The following is a description of a gene set: Genes down-regulated in comparison of lineage negative versus B cells. studied in species Homo sapiens Human Gene Set: GSE27786_LIN_NEG_VS_BCELL_DN Each fraction of mouse hematopoietic cells was purified by cell sorting from bone marrow of 8-week-old C57BL/6 mice, and its gene expression was analyzed. from publication Konuma T, Nakamura S, Miyagi S, Negishi M, Chiba T, Oguro H, Yuan J, Mochizuki-Kashio M, Ichikawa H, Miyoshi H, Vidal M, Iwama A (PMID 21540074), and this is the list of marker genes: TMEM229B, GBP4, TMA7, RIC8A, ZNF264, PGGT1B, DCAF11, CCND2, CACTIN, MOB3C (NCBI Gene Id 148932), RPS19, SYNE2, UFM1, SEPTIN7, CMTR1, CLTA, RNF19B, ZMYM5, SSH3, SF3B2, MTARC2, MPND, RAB39A, SCAPER, PFKFB4, ADAMTS6, BABAM1, BAZ2B, SETD2, POLDIP3, KDM1B, GGNBP2, ZNF383 (zinc finger protein 383), TMEM9B, MALAT1, SNF8, TAF8, ZNF740, STARD5, KRTCAP2, ANTXR2 (ANTXR cell adhesion molecule 2), RPL31, GCNT1, MAPK12, MIR22HG, DGKQ, KIF1C, BFAR, IGKC, RLF, ARHGEF1, RFTN1, CHST8, NXPE3, PAN3, STAT1, CNPY4, TBC1D17 (NCBI Gene Id 79735), UBL5, GCC2, SMAGP, DHX57, DCUN1D1, PHLPP1, FGD3, SAPCD1, FGF17, CCDC88C, RDH12, CPSF3, TBC1D20, NDUFAF3 (NADH:ubiquinone oxidoreductase complex assembly factor 3), KIF12, TRIM5, SNX29, EAPP, KMT2D, CWC25, MTMR14, USP12, RABGAP1L (RAB GTPase activating protein 1 like), NAA60, CEP164, PSMB9, PHIP, RFLNA, CHD3, CABP2, KIF21B, MAP3K2, LYST, GIMAP4 (GTPase, IMAP family member 4), UBE2B, TMEM234, NIPAL3, PDE4DIP, STIM2, WASHC2A, TRAF3IP3, FAM167A, NDFIP2, DDX59, COMMD4, MGA, PML, OSBPL11, PLEKHG2, RBM10, PLPPR1, TMEM62, CXorf38, ZFP36L1, DMAC2, BCKDHA, FBXO11, AGAP2, ANKRD2, DUSP16, HSD17B11, NCOA6, IFT22, CALHM2 (calcium homeostasis modulator family member 2), RPS8, THOC2, GPSM3, MAGI3, DIPK1A, LYPLA2, BRI3, SCP2 (NCBI Gene Id 6342), FBXL5, SRF, SPOP, NCKAP1L, MGAT5B (NCBI Gene Id 283995), RPP25L, TRIM39, SSU72, STBD1, CLK3 (CDC like kinase 3), PSMA5, CCDC47, ERP27, TMF1, FIS1, FOXD2, CHD6, G3BP2, CYP39A1, TUBA1A, CD1D, ATP10D, CDK9, TUT4, DEDD, SQSTM1 (sequestosome 1), TBX6, ANXA6, IP6K1, PPP1R21, FCGRT, IKZF1, CHIC2, DDX5, SH3BP2, CD164, ICAM1, SEC63, EHD2, DTX2, SUFU, SBNO1, AMZ1, ESCO1, USE1, TRHDE, RNF167, RPS15A, CYTH4, EDARADD, CDIP1, ZSWIM8 (NCBI Gene Id 23053), ANKRD11, PARP3, ESF1, PAF1 (NCBI Gene Id 54623), LTA, FAM120B, OAS2, SZT2, ARMC3, KMT2A, ENOX2, TNNC2, YKT6, SAP30BP, HGH1, C9orf85, FCGR2B, HIGD2A